Given this list of marker genes RFX7, IQSEC2, NTRK1, FLII, RAI1, DEAF1, PIDD1, here is a description of the gene set: Habitual biting of one's own fingernails. Nail-biting Human Gene Set: HP_NAIL_BITING species: Homo sapiens